The following is a description of a gene set: Genes up-regulated in T reg: peripheral lymph nodes versus thymic CD24 high. We investigated at which stage of maturation commitment to a stable Foxp3-expressing phenotype takes place. We assessed stability of Foxp3 expression in thymic Foxp3+ Treg subsets of different maturity, defined by CD24 expression. Next we compared gene expression profiles of Foxp3+ Treg subsets (+) of different maturity (24lo, 24int, 24hi) and could identify a set of genes that were specifically up or downregulated in Foxp3+ Tregs, but not in Foxp3- conventional T cells, in a maturation-dependent manner. from publication Toker A, Engelbert D, Garg G, Polansky JK, Floess S, Miyao T, Baron U, Düber S, Geffers R, Giehr P, Schallenberg S, Kretschmer K, Olek S, Walter J, Weiss S, Hori S, Hamann A, Huehn J (PMID 23420886) Human Gene Set: GSE42021_TREG_PLN_VS_CD24HI_TREG_THYMUS_UP studied in species Homo sapiens, and this is the list of marker genes: TBRG4, PLXNA3 (plexin A3), ATP6V1H, RBM18, NFE2L2, IGF2, MYC, IGF2BP1, LDAF1, ETF1, RIOK3, PLAUR, RAD51B, DNAAF10, HSP90AA1, TES, EXOSC5, ICAM1, CXCL2, IFRD1, ZFP36L1, PDGFA, CPEB2, MADCAM1, TGIF1, C2CD2, CLCN4, FBLN2, SMARCA2, TSHB, ILF3, CD83, MYL4, F2RL3, HLA-A, CAVIN1 (caveolae associated protein 1), MFSD14A, GDPD3, ZFP62, DLD, GRIN2B, LGALS4, UTP4, GADD45B, CLEC4D, EHD1, PPIC, FOS, GJA1, SRGN, CUL2, ARPP19, NDEL1, CLEC4E, MMP12, SLC20A1, ZFP1, DNAJA1, NUPR1, ARIH2, HNRNPK, TXNRD1, KDELR3, PAK1IP1, ZNF706 (NCBI Gene Id 51123), ANGPTL2, CCL13, SOCS3, RMND5A, DDX46, NFKBIA, SQSTM1, MEF2D, GTPBP4, NUP88, KCMF1, UPP1, SLC30A3, SMAP1, ACSL4, COPS4, DDX3Y (DEAD-box helicase 3 Y-linked), ANKRD28, NCOA6, CXCL3, RPL31, FAU, EGR1, SNCB, TRA2B, LAPTM4A, NF1 (NCBI Gene Id 646021), DUSP1, NPY2R, TAX1BP1, SPG21, MARCHF7, TSR1, EIF5, SLC25A15, MARCKSL1, MOB1B, RAB12, BIRC3, NPY1R, KCTD12, UGDH, EEA1, IL1A, ELAC2, IL1RN, FAM83H, ARF6 (ADP ribosylation factor 6), PELI1, AASS, BTG3, EI24, IL1B, LIN7C, AAK1, ERRFI1, UGCG, IRF1, RAB18, FN1, RELB, RHOB, STAT4, BHLHE40 (basic helix-loop-helix family member e40), EEIG1, YES1, GSTM3, MDM2, VCL, DUSP2, CLTC, SRY, CPE, CD14, PSCA, PTGS2, MAP2K4, NR4A1, CEBPB, ZNF644, IST1, KRAS, NOTCH2, SERPINH1, JUNB, PIM1, RREB1, CCL7, PHLDA1, LRRC58, TNFAIP2, IL10, SGK1, CRABP2, B4GALT1 (NCBI Gene Id 2683), DAZAP1, MMP14 (NCBI Gene Id 4323), TANK, PCSK6, GTF2E2, SERPINE1, NFKBIZ, DDX5, SMAD6, DHX15, STK40, ID1, CPLX1, SLC30A4, CTPS1 (NCBI Gene Id 1503), IER3, PIAS2, HOXD8, TNF, EGR2, BTG2, IER2, ELF3, IL7, PPP3CA, TMC6, TOP1, CDKN1A, FRRS1, ABRACL, ETS2, ATP13A3, CHPF, TNFSF9, UBA3, PPP1R15A, DNAJB6, DPP6, CACNA2D1, IL27RA